The following is a description of a gene set: Human Gene Set: GOBP_REGULATION_OF_AMINO_ACID_TRANSPORT species: Homo sapiens Any process that modulates the frequency, rate or extent of the directed movement of amino acids into, out of or within a cell, or between cells, by means of some agent such as a transporter or pore., and this is the list of marker genes: SLC43A2, TRH, ACE2 (angiotensin converting enzyme 2), RGS2, NTSR1, KMO, ABAT, NPY5R, GRM7, TNF, ATP1A2, LEP, SLC38A2, PRKG1, ARL6IP5, GRM2, SLC7A5, PSEN1, RAB3GAP1, ITGB1, P2RX7, AVPR1A, AVP, SLC12A2, SYT4, STXBP1, SNCA, SEPTIN2, ADORA2A, SLC43A1, GABBR1, ARL6IP1, RGS4, DTNBP1, SLC17A8, PER2 (NCBI Gene Id 8864), CLTRN, ADORA1, SLC38A3